The following is a description of a gene set: Mouse Gene Set: GOBP_VASCULOGENESIS_INVOLVED_IN_CORONARY_VASCULAR_MORPHOGENESIS The differentiation of endothelial cells from progenitor cells that contributes to blood vessel development in the heart, and the de novo formation of blood vessels and tubes. species: Mus musculus, and this is the list of marker genes: Fgf1, Fgf9, Notch1, Fgfr2, Gata4, Epo, Epor, Spred1, Angpt1, Zfpm2, Fgfr1, Pbrm1, Prok2, Shh, Tgfbr3, Nrp1